Given this list of marker genes GNAS, CPS1, GLP1R, ADCY8, GCG, GLP2R, FUT1, ASS1, PRKACA, GCGR, PRKAR1A, here is a description of the gene set: Human Gene Set: GOBP_CELLULAR_RESPONSE_TO_GLUCAGON_STIMULUS species: Homo sapiens Any process that results in a change in state or activity of a cell (in terms of movement, secretion, enzyme production, gene expression, etc.) as a result of a glucagon stimulus.